The following is a description of a gene set: Th1 and Th2 cells arise from a common precursor cell in response to triggering through the TCR and cytokine receptors for IL-12 or IL-4. This leads to activation of complex signaling pathways, which are not known in detail. Disturbances in the balance between type 1 and type 2 responses can lead to certain immune-mediated diseases. Thus, it is important to understand how Th1 and Th2 cells are generated. To clarify the mechanisms as to how IL-12 and IL-4 induce Th1 and Th2 differentiation and how TGF-beta can inhibit this process, we have used oligonucleotide arrays to examine the early polarization of Th1 and Th2 cells in the presence and absence of TGF-beta after 0, 2, 6 and 48 hours of polarization. from publication Lund R, Aittokallio T, Nevalainen O, Lahesmaa R (PMID 14607935) Human Gene Set: GSE2770_IL12_VS_TGFB_AND_IL12_TREATED_ACT_CD4_TCELL_2H_UP Genes up-regulated in CD4 T cells activated by anti-CD3 and anti-CD28: IL-12 (2h) versus TGFB1 and IL-12 (2h). species: Homo sapiens, and this is the list of marker genes: CCDC88A, DNAJC17, AIRN, CFI, CORO1B, AGXT2, CREB3L3, ACP1, CTSW, DIMT1, DND1, E2F8, CCNA2, CCDC61, AGAP1, AQP11, ABL1, CLSTN1, CHD3, CEP83, ADM2, CNTN4, DACT3, TOLLIP, ANKRD33B, CDHR4, ALDH9A1, CSTB, GRK2, PCARE, CNPY4, CLUAP1, BCL2L14, CLIP4, CCNI, CORO6, CREBL2, CXCL3, ABTB1, ARFGEF2, DIO1, DMRTC1B, AFAP1L2, CRB2, CAMSAP2, C2CD4C, AREG, CELA1, B3GNT9, DACT2, DUOX1, DTWD2, DMRTA2, ACTBL2, CBY3, DBR1 (debranching RNA lariats 1), CTTNBP2, BOLA1, ARF4, CEP57, CPZ, CIMAP2, CORIN, CCDC125, CD6, COL2A1, ADAMTS6, COMMD2, DLG5, COX16, ABCD2, CNOT2, CDK13, ATG2B, BDKRB2, DIDO1, ANKK1, CCNF, CEP63, DTNBP1, CDKN1C, CHURC1, CSMD1, AKT1, CYTH4, DPY19L3, CEACAM19, ARPP19, CCR6, EDC3, CYP2R1, PRRC2B, CPNE4, ATP6V1A, DGKI, CSTF1, CTBP2, ADAM30, ALG11, DTL, ALG10B, CAMSAP1, CDK5RAP3, CHRM1, CCDC54, NAXE, ATP6V1D, CBY1, ALG14, CCDC152, ECH1, CPSF4L, BMP15, GPRASP3, BGN, BCAM, BTBD2, CPB2, DOCK11, ECSIT, CD300C (CD300c molecule), CACHD1, ANKS6, ADORA2B, CHRNA2, CARD6, ACTN2